The following is a description of a gene set: species: Homo sapiens part of: Fatty acid metabolism Beta-oxidation begins once fatty acids have been imported into the mitochondrial matrix by carnitine acyltransferases. The beta-oxidation spiral of fatty acids metabolism involves the repetitive removal of two carbon units from the fatty acyl chain. There are four steps to this process: oxidation, hydration, a second oxidation, and finally thiolysis. The last step releases the two-carbon acetyl-CoA and a ready primed acyl-CoA that takes another turn down the spiral. In total each turn of the beta-oxidation spiral produces one NADH, one FADH2, and one acetyl-CoA.<p>Further oxidation of acetyl-CoA via the tricarboxylic acid cycle generates additional FADH2 and NADH. All reduced cofactors are used by the mitochondrial electron transport chain to form ATP. The complete oxidation of a fatty acid molecule produces numerous ATP molecules. Palmitate, used as the model here, produces 129 ATPs.<p>Beta-oxidation pathways differ for saturated and unsaturated fatty acids. The beta-oxidation of saturated fatty acids requires four different enzymatic steps. Beta-oxidation produces and consumes intermediates with a trans configuration; unsaturated fatty acids that have bonds in the cis configuration require three separate enzymatic steps to prepare these molecules for the beta-oxidation pathway. Reactome Pathway: Mitochondrial Fatty Acid Beta-Oxidation, and this is the list of marker genes: ACOT1, ACAD10, ACBD7, ACOT7L, ACSF2, ACAD11, MMAA (metabolism of cobalamin associated A), MCAT, HADHB, ECI1, THEM5, ACADL, ECHS1, NDUFAB1, ACOT2, ACAA2, MECR, ACBD6, PCTP, MCEE, HADH, THEM4, ACADVL, MMUT, ACOT9, ACOT11, ACSM3 (acyl-CoA synthetase medium chain family member 3), ACSM6, DECR1, DBI, ACOT12, ACOT13, PCCB, ACADM, ACOT7, HADHA, ACADS, PCCA